The following is a description of a gene set: from publication Xie X, Lu J, Kulbokas EJ, Golub TR, Mootha V, Lindblad-Toh K, Lander ES, Kellis M (PMID 15735639) Human Gene Set: GKCGCNNNNNNNTGAYG_UNKNOWN studied in species Homo sapiens Comprehensive identification of all functional elements encoded in the human genome is a fundamental need in biomedical research. Here, we present a comparative analysis of the human, mouse, rat and dog genomes to create a systematic catalogue of common regulatory motifs in promoters and 3' untranslated regions (3' UTRs). The promoter analysis yields 174 candidate motifs, including most previously known transcription-factor binding sites and 105 new motifs. The 3'-UTR analysis yields 106 motifs likely to be involved in post-transcriptional regulation. Nearly one-half are associated with microRNAs (miRNAs), leading to the discovery of many new miRNA genes and their likely target genes. Our results suggest that previous estimates of the number of human miRNA genes were low, and that miRNAs regulate at least 20% of human genes. The overall results provide a systematic view of gene regulation in the human, which will be refined as additional mammalian genomes become available. Genes having at least one occurrence of the highly conserved motif M19 GKCGCNNNNNNNTGAYG in the regions spanning 4 kb centered on their transcription starting sites. The motif does not match any known transcription factor binding site., and this is the list of marker genes: BCL2L2, NEK1, RCE1, NUP155, CNOT7, TRAK2, MECR, MFN2 (NCBI Gene Id 9927), ADPGK, GTF3C2, MUL1, COQ7, PSMB2, PWP1, ORMDL3, DNAJB11, RANBP2, RNF7, QTRT2, AOPEP, UBE4A, SPACA9, ZC3H18, STRADB, UXT, PHF7, MRPL49, ZNF367, ABCE1, CCDC191, ANAPC10, RNF141, PHF5A (NCBI Gene Id 84844), DHRS1, NOP9, NUP153, BAP1, NUP42, NUBPL, LDAH, FAU, ATG5, VPS37A, SNF8, NUP133, PHF20L1, ACO2, ZNF644, GPAM, PINX1, AK8, RFC1, PSME3, LCMT1, TRMT61B, BRMS1, SENP2, CCDC86, RNPS1, NFX1